The following is a description of a gene set: studied in species Mus musculus Mouse Gene Set: GOBP_POSITIVE_REGULATION_OF_NEURON_MATURATION Any process that activates or increases the frequency, rate or extent of neuron maturation., and this is the list of marker genes: Ngf, Opa1, Grip2, Ret, Mtor, Bcl2, Map3k13